Given this list of marker genes ZNF117, PTGFRN, CHUK, RPS6KA5, TAOK1, ZNF681, EPDR1, N4BP2L2, ELAVL4, CDKL3, ELAPOR2, EDIL3, BNC1 (basonuclin zinc finger protein 1), EIF2AK3, CELF4, SLAIN2 (NCBI Gene Id 80106), CUL5, AASDHPPT, C2orf49, RPGR, CNOT6, FBN1, RSBN1L, P2RY13, PAFAH1B1, PABIR1 (NCBI Gene Id 116224), BRWD3, ZNF98, ELAVL1, TRA2A, CCNK, UGT2A1, TSPAN6, ATP11A, KCTD10, ABCB10, PPP1CB, LINGO2, ATP6V1A, S100A7A, KDM2A, FIGN, ADNP, UHMK1, TMEM255A (NCBI Gene Id 55026), MAP3K5, PCDH18, PURG, ELOVL5, MRPL47, NCAM1, POTEA, YY1 (YY1 transcription factor), ATF7IP, ETNK1, SLC7A11, ZFP90, NUFIP2, ZNF850, ZFX, KIAA1217, CSTF1, SOWAHC, RAB14, PNRC1, PCYOX1, VDAC3, NHS, TMEM108, FANCI, TMED3, LMLN, GASK1A, ASB5, PHKA1, PABIR2, KHDRBS1, PTP4A1, ITGA6, ABHD13, BCL6B, PHF14, RAD51C, NTRK2, TIMM8B, XPO7, SNX30, RAB39B, TP63, TENT4B, ZNF506, KDM6B, ARIH1, PRDM2, PPP6R3, CCR9, CEP350, GXYLT1, NSUN7, RNF115, TANC2, QSER1, NXPH2, MATR3, C1QL3, TTC39C, ZNF189, FGD4, DTNBP1, UGT2A2, SLC43A2, CRBN, CCND2, ADAMTS8, CD2, SRL, BMP2K, ZNF257 (NCBI Gene Id 113835), CTNND1, ID4, BIVM, CTNNA2, HORMAD2, KALRN, RLF, ZNF605, OCIAD1 (OCIA domain containing 1), RFX4, GPR137C, DIPK1C, here is a description of the gene set: from publication Chen Y, Wang X (PMID 31504780) Human Gene Set: MIR216B_3P Genes predicted to be targets of miRBase v22 microRNA hsa-miR-216b-3p in miRDB v6.0 with MirTarget v4 prediction scores > 80 (high confidence targets). studied in species Homo sapiens